Given this list of marker genes HBB, HBG1, HBG2, KLF1, GBA1, SCARB2, BCL11A, here is a description of the gene set: Ischemia and necrosis of part or all of the spleen resulting from compromise of blood supply resulting from arterial or venous occlusion. Human Gene Set: HP_SPLENIC_INFARCTION Splenic infarction studied in species Homo sapiens